The following is a description of a gene set: Genes down-regulated in bone marrow-derived macrophages at 45 min of stimulation by IL6 and LPS: wildtype versus IL6 knockout. from publication El Kasmi KC, Holst J, Coffre M, Mielke L, de Pauw A, Lhocine N, Smith AM, Rutschman R, Kaushal D, Shen Y, Suda T, Donnelly RP, Myers MG Jr, Alexander W, Vignali DA, Watowich SS, Ernst M, Hilton DJ, Murray PJ (PMID 17114459) Human Gene Set: GSE5589_WT_VS_IL6_KO_LPS_AND_IL6_STIM_MACROPHAGE_45MIN_DN studied in species Homo sapiens IL-10 or IL-6 stimulation of control 129xC57BL/6 murine bone marrow derived macrophages in the presence of LPS. We used microarrays to detail the global programme of gene expression changes in response to IL-6 or IL-10 stimulation in the presence of lipopolysaccharide. BMDMs were isolated from control, IL-6-/-, and IL-10-/- mice on a 129XBL/6 mixed background mice and differentiated in the presence of CSF-1 for 6-7 days. Cells were scraped and plated in 6 well plates at 2x10e6/well. Cells were washed with complete DMEM and rested for 1-2 hr before stimulation with combinations of IL-10 (10 ng/ml), IL-6 (2 ng/ml) or LPS (100 ng/ml) for 45 min or 180 mins. Complete biological replicates were performed., and this is the list of marker genes: SYK, MAPK8IP3, CASP8, STARD5, PHKA2, TMEM41B, SERPINE1, SEPTIN9, EIF3C, XRN2, PRXL2B (NCBI Gene Id 127281), GNAI3, LIMA1, TMEM135, SLCO2B1, PCYT2, SHISA9, SLC27A4, NEDD9, DDX46, C11orf54, SLC15A1, C6orf141, RAPH1, CDK17, ASB4, TNFRSF21, WDR25, AQP1, PIP5KL1, GSTO1, EML1, LPCAT3, CAVIN1 (NCBI Gene Id 284119), CHKB, SMOX, ADIPOR2, HSPB6, HADHB, PWWP3B, PANK3, MGST2, CSPG4, LAMA3, CLCN4, FGF7, PCOLCE2, SCARA3, ACADS, COL4A1, CYP51A1, TALDO1, CRIP2, ARFIP2, SEMA6D, CCDC61, MCEMP1, SAMD4A, IFRD2, RUNX1T1, PECR (peroxisomal trans-2-enoyl-CoA reductase), RHOBTB3 (Rho related BTB domain containing 3), PKP2, NCOR2, CAV1, PCOLCE, ABHD12, CEP15, TMEM65, IDH3G, CD48, RUNX2, SORT1, EREG, STAB2, IQSEC1, NID1, ECH1, FGFR1, SLC25A51, SPTLC2, VASN, ASPA (NCBI Gene Id 443), TEF, F7, NEDD4, MGAT4B, PTGIS, PDE1B (phosphodiesterase 1B), NCKAP1, CD36, PLEKHA5, H6PD, GLIS3, CANT1, PHPT1, SON, GEMIN5, CCDC183, MAN1C1, B3GLCT, FRK, SLC20A2, ACAA2, TMEM45A, WWP1, PLPP1, BLTP3B, REV3L, ANGPTL4, PRRX2, ELK3, TGFBRAP1, CDC14B, ABHD3, PCDH7, P4HB, CHAMP1, TBC1D20, ITGAV, KIDINS220, FAM168B, ZDHHC9 (zinc finger DHHC-type palmitoyltransferase 9), EVI5, MYO9A, CCDC17, TMEM26 (NCBI Gene Id 219623), VCAM1, MAOA, TBC1D2, NPC1, PHLDB2, FBLN2, AOC3, GET1, PLXDC2, ANGPTL3, DCLK1, GRB10, OSMR, DCN, CPOX (NCBI Gene Id 201541), NUDT6, GPX8, KCNQ1OT1, ERI3, RNF144B, EIF3A, ENPP1, SLC5A3, UBP1 (upstream binding protein 1), TNRC6A, PCDH1, MRC2, LOX, SYNE2, CAPZA3, AFMID, PRPSAP1, AGPAT3, GRK2, FABP7, HYCC1, S100A1, DOCK7, IGFBP6, FKTN, TSPAN33, BAHD1, HEBP1, RAB29, SCD, ARL6IP1, CCNT2, OLFML3, AVPI1, PLCXD2, SLC37A2, CDH2, COL4A2, GPD1L, NR1H3, MROH1, OAF, TM4SF1, LRPPRC, SERPINB6, IQGAP1, PLIN2, PRICKLE2, CCBE1, PPT2, ING4, LRRC39, DUSP11, UPF3B, TPRA1, CPE, SNRNP200